The following is a description of a gene set: Cytoarchitectural abnormalities have been described in the prefrontal cortex of subjects with schizophrenia, bipolar disorder and depression. However, little is known about the gene expression profiles associated with these abnormalities. Genome-wide expression profiling technology provides an unbiased approach to identifying candidate genes and biological processes that may be associated with complex biological traits such as cytoarchitecture. In this study, we explored expression profiles associated with the abnormalities by using publicly available microarray metadata and cytoarchitectural data from post-mortem samples of the frontal cortex from 54 subjects (schizophrenia, n=14; bipolar disorder, n=13; depression, n=12 and controls n=15). Correlation analysis between genome-wide expression levels and cytoarchitectural traits revealed that genes were significantly correlated with a decrease in the number of perineuronal oligodendrocytes across all subjects. A total of genes were significantly correlated with a decrease in density of calbindin-positive interneurons across all subjects. Multiple biological processes including cellular metabolism, central nervous system development, cell motility and programmed cell death were significantly overrepresented in both correlated gene lists. These findings may provide novel insights into the molecular mechanisms that underlie the cytoarchitectural abnormalities of perineuronal oligodendrocytes and calbindin-containing GABAergic interneurons in the prefrontal cortex of the major psychiatric disorders. Human Gene Set: KIM_ALL_DISORDERS_CALB1_CORR_DN studied in species Homo sapiens Genes whose expression significantly and negatively correlated with the density of CALB1-positive GABAergic interneurons in the BA9 brain region across all subjects with psychiatric disorders. from publication Kim S, Webster MJ (PMID 18762803), and this is the list of marker genes: INPP5D, S100A8, XRCC3, RREB1, DDX11, ALX1, KRT1, GADD45B, ALDH3A1, IFNA6, SLC16A6, LHCGR (luteinizing hormone/choriogonadotropin receptor), LCOR, SSTR3, CTSG, ROR2, LINC00837, TM4SF5, KLRC3, CCL1, S100A4, GFI1, CD40, APOBEC3C, DAPK2, IL1RAP, CCIN, NR5A1, SBNO2, GIP, SLC22A13, CHIT1, HSD3B2, ANPEP, AQP7, PXN